The following is a description of a gene set: studied in species Mus musculus The cleavage of DNA during apoptosis, which usually occurs in two stages: cleavage into fragments of about 50 kbp followed by cleavage between nucleosomes to yield 200 bp fragments. Mouse Gene Set: GOBP_APOPTOTIC_DNA_FRAGMENTATION, and this is the list of marker genes: Foxl2, Apaf1, Nmnat1, Cidea, Bax, Aifm1, Dffb, Dffa, Dicer1, Hsf1, Dnase1l3, Cdkn2a, Blvra, Dnase2b, Endog, Gata5, Igfbp3, Il6, Vps54, Exog, Dnase2a